Given this list of marker genes Tomm34, Atp10a, Elavl1, Csdc2, Vcl, Ppfia4, Fbxo42, Rph3a, Retreg3, Pecam1, Cd4, Trnp1, Phactr2, Kif7, Klhl41, Adtrp, Upf2, Mastl, Atad1, Vwa1, Dexi, here is a description of the gene set: Mouse Gene Set: MIR_7085_5P studied in species Mus musculus from publication Chen Y, Wang X (PMID 31504780) Genes predicted to be targets of miRBase v22 microRNA mmu_miR_7085_5p in miRDB v6.0 with MirTarget v4 prediction scores > 80 (high confidence targets).